The following is a description of a gene set: studied in species Homo sapiens Any process that modulates the frequency, rate or extent of mitochondrial electron transport, NADH to ubiquinone. Human Gene Set: GOBP_REGULATION_OF_MITOCHONDRIAL_ELECTRON_TRANSPORT_NADH_TO_UBIQUINONE, and this is the list of marker genes: MIR210, PARK7, DNAJC15, PINK1, ISCU, SNCA